Given this list of marker genes PHF10, KCNQ3, HGD, CHI3L2, BBS9, CLEC4A, PIK3C2A, CABS1, QSER1, RETREG1, CERS6, LINC01252, ANKRD29, UBR3, GJB6, HNRNPH1, CFAP54, FASTKD5, RIMKLA, BCL10, BEX1, E2F6, CDH12, SPINT2, EBF2, C8orf34, KIF13A, SERINC5, LDLRAP1, ZNF280D (zinc finger protein 280D), WNT8A, PPCS, LINC01181, VNN2, ORC2, ACTR3B, CCDC144A, DCAF4L1, THAP6, PLAG1 (PLAG1 zinc finger), DPY19L4, KCNA5, THAP5, GKAP1, AP3M2, RMND5B, N4BP2, CR2, CEP135, FERRY3, SAPCD2, VCPKMT, APOB, HNRNPA2B1, CENPC, IDNK, OR13C4, DCAF10, ZNF107, HECTD2, TRABD2A, FAT3, NAP1L3, TIMP2, PIP4P2, TMEM218, ART1, PARS2, CES4A, KRT84, ZBTB33, FAM184A, MAPK8, SLC7A6OS, ERBB4, CIBAR1, AP5M1, CAND2, SPART, MDS2, MARCHF3, ARB2A, ZNF558, C2orf74, MAP3K4, ZNF83, SLC11A2, TC2N, IPMK, KLHL3, DLL1, SSBP2, LARGE1, TMED7, PCSK5, CDC6, GALNT1, SEC16A, NFX1, NRIP1, ZNF23, LINC02796, BBS2, ACTN1, SLC8B1, TENT5B, DRAM2, INPP4B, SEPHS1, NDUFS4, YES1, ZSWIM6, SFMBT2, FUT3, XRCC4, GAL3ST4, FAM53C, DHX15, GALNT12, NEK9, SPEN-AS1, LINC00173, KDM2A, KDF1, KRCC1, TRADD, PEX7, GEMIN4, C1orf54, AUH, WDR27, BEX3, RABGGTB, HSPH1, FRAS1, LYRM9, ADAMTS9-AS2, TMEM17, SLC38A6, TLK1, PPP4R4, RIF1 (replication timing regulatory factor 1), TGM7, PABPC3, TAFA1, TCEA3, ARHGEF28, KLHDC1, PLPP6, HEATR5A, KLHL29, NPAP1, PTBP2, KCNK1, SLC39A10, ZNF10, ERCC6L2-AS1, BCL2A1, XPNPEP3, SPRR1B, GOPC, FILIP1L, TXK, COL1A2, IGF1R, ABITRAM, EIF5A, NIF3L1, TMEM232, CPVL-AS2, NEUROD2, FGF8, UFL1, PAN3, HERC4, SART3, MYCBP2, MBIP, LINC02731, FAM220A, ZMYM2, TMEM80, ASB8, SDCBP, AICDA, SHANK3, FAM241A, STRADB, SPDYE1, TMEM123, TOP1MT, ZNF682 (zinc finger protein 682), AFF4, SNX29, here is a description of the gene set: studied in species Homo sapiens from publication Chevalier N, Jarrossay D, Ho E, Avery DT, Ma CS, Yu D, Sallusto F, Tangye SG, Mackay CR (PMID 21471443) Human Gene Set: GSE26928_EFF_MEMORY_VS_CXCR5_POS_CD4_TCELL_DN Genes down-regulated in comparison of CD4 effector memory T cells versus CD4 CXCR5+ T cells.